The following is a description of a gene set: Human Gene Set: REACTOME_RESOLUTION_OF_D_LOOP_STRUCTURES studied in species Homo sapiens Resolution of D-Loop Structures, and this is the list of marker genes: EXO1, SLX4, SLX1B, SLX1A, XRCC3, GEN1, PALB2, TOP3A, BRIP1, ATM, MRE11, SPIDR (scaffold protein involved in DNA repair), RAD50, NBN (NCBI Gene Id 4683), FIGNL1, RAD51D, BLM, RAD51 (NCBI Gene Id 5888), BRCA2, FIRRM, BARD1, RBBP8, EME1, SEM1, RMI1, RTEL1, RAD51B, RAD51AP1, BRCA1, KAT5, XRCC2, RAD51C, DNA2 (DNA replication helicase/nuclease 2), WRN, MUS81, EME2, RMI2